The following is a description of a gene set: studied in species Mus musculus Any process that modulates the frequency, rate or extent of muscle cell differentiation. Mouse Gene Set: GOBP_REGULATION_OF_MUSCLE_CELL_DIFFERENTIATION, and this is the list of marker genes: Notch4, Igf2, Fdps, Pak1, Fzd7, Hamp, Hdac5, Mesp1, Shox2, Kat2a, Sox6, Bdnf, Pi16, Sirt1, Igf1, Nln, Cyp26b1 (cytochrome P450, family 26, subfamily b, polypeptide 1), Smad4, Bcl2, Edn1, Cdk9, Dnmt1, Fgfr2, Tmem119, Efnb2, Eng, Ankrd17, Tshz3, Lamc1, Fbxo22, Lamb1, Atp11a, Parp2, Id2, Nid1, Ccn4, Tgfb1, Kit, Sik1, Mtor, Myocd, Bmpr1a, Lamb2, Camk1, Csrp3, Nfatc3, Mdm2, Trim72, Bmp10, Prox1 (NCBI Gene Id 320240), Dmpk, Csf1r, Gper1, Nkx2-5, Notch1, Pdcd4, Rbm4, G6pdx, Yy1, Akirin2, Rbpms2, Akap6, Neu2, Mapk14, Tbx1, Pdgfb, Mylk3, Lama2, Tmsb4x, Sod2, Trip10, Smyd1, Bhlhe41, Ddx39b, Hamp2, Ptbp1, Ctdp1, Mecp2, Myf5, Olfm2, Piezo1, Wnt3a (wingless-type MMTV integration site family, member 3A), Zbed6, Rpl3l, Tcf23, Myog, Hdac4, Ankrd2, Efemp2, Zfp418 (NCBI Gene Id 232854), Dkk1, Hey2, Rgs2, Rbm24, Adrb1, Nfatc2, Fgf9, Bhlha15, Actn3, Epc1, Ep300, Ccnd2, Msx1, Hey1, Arrb2, Morf4l2, Cav3, Pin1, Gsk3b, Tomm70a, Megf10, Bmpr2, Cth, Hdac3, Smad1, Pin1rt1, Frs2, Lmod3, Nr3c1, Ppara, Shh, Tnpo2, Mef2c, Ccn3, G6pd2, Foxo4, Foxp1, Daxx, Smarcd3, Mamstr, Hopx, Nrg1, Tarbp2, Eif5a, Slc25a4, Trim32, Dll1, Prkd1, Bmp4, Rcan1, Med28, Rbm38, Rgs4, Plpp7, Zeb1, Hdac9, Lama1, Nfatc1, Rbm10, Ccnt2, Ereg, Supt6, Myf6, Xbp1 (X-box binding protein 1), Setd3, Ezh2, Gsk3a, Nek5, Myod1, Maml1, Notch2, Bmp2, Or10j5, Pias1, Prdm6, Ybx1, Mmp14